Given this list of marker genes TXNRD2, STAR, MC2R, NNT, MRAP, here is a description of the gene set: Failure of cortisol levels to respond adequately (by increasing) to the insulin tolerance test (ITT). Human Gene Set: HP_IMPAIRED_CORTISOL_RESPONSE_TO_INSULIN_STIMULATION_TEST Impaired cortisol response to insulin stimulation test studied in species Homo sapiens